The following is a description of a gene set: species: Homo sapiens Increased body weight with a body mass index of 25-29.9 kg per square meter. Human Gene Set: HP_OVERWEIGHT Overweight, and this is the list of marker genes: UNC45B, MYT1L, KCNJ11, ZBTB7A, SATB1 (SATB homeobox 1), CFAP418, TRHR, BLK, ABCB4, SPG11, CEL, LHX4, AP1S3, INS, EHMT1, KLF11, SPTBN1, CHD8 (chromodomain helicase DNA binding protein 8), TRIP4, NEUROD1, AP4E1, TAOK1, LMNA, IL36RN, IGSF1, ADGRL1, APPL1 (NCBI Gene Id 26060), HESX1, CREBBP, HNF4A, AP4B1, ABCC8, ACADVL, AP4S1, HNF1A, PAX4 (paired box 4), LHX3, PDX1, SLC9A7, CTSK, AP4M1 (NCBI Gene Id 9179), GCK, FOXP1, PDSS1, USP7, PROP1, ASH1L, THOC2, POU1F1, TMEM218